Given this list of marker genes COP1, CTU1 (cytosolic thiouridylase subunit 1), SPATS2L, RNF145, NRP2, ZDHHC17, ERN1, TMEM170B, RCN1, NFIX, ADH7 (NCBI Gene Id 131), TMEM128, ACBD3, DTX4, HCLS1, NUP58, PNPT1, NPLOC4, CCND2, SLC39A1, UTP4, LINC02291, ATF4, SLFN12, PNP, ASF1A, IRGM, PTCH1, TERT, RARRES1, PRR14L, TRA2B, ZCCHC9, ITGAL, PPP1CB, TMEM176B, PARP12, DIS3, ZFAND3, ABITRAM, AMMECR1L, MAPK9, RND1, CASP7, UNC5A, PGGT1B, PLSCR1, PIAS1, FOXP4, RSPO2, CDKN1A, ARHGEF3, ITGA8, USP42, MTHFD2, PIK3R3, AK2, ROBO1, PRKD1, ZNF784, HAPSTR1, ADAMTS1, SLC39A14, PRDM1, LRCH3, TOMM20, TPD52L2, PTPN12, MOB1B, JADE1, PYCR1, TBC1D12, IL1RN, LHFPL6, SLC28A2, TXNRD1, POLR1F, ANXA7, CFB, DNMT3L, SOCS2, SYT13, BLNK, COL12A1, GPR85, UAP1, BACE1, ELP5, DIP2C, UBA3, PHTF2, PSMA6, CYFIP2, NSUN5, TTC39B, TLR3, FOXN2, FGF7, PER2, XAF1, GAS7, EPB41L3, COL27A1, KDELR3, MAGI3, MPRIP (myosin phosphatase Rho interacting protein), ATF1, CABLES2, PPP1R11, SLFN13, CD86, ZNRF1, WFS1, RSRC2, PDS5B, RAB11A, GARS1, STK40, IFT57, NEK4, TRAF3, TCF7L2 (NCBI Gene Id 6934), GPRIN3, NDUFAF4, GAS1, CEMIP (NCBI Gene Id 57214), PLEKHN1, BMP15, MS4A6A, PSMB10, STAT1, CGAS, LARP6, RIGI, TEAD1, SRSF3, NUPR1 (nuclear protein 1, transcriptional regulator), ZC3HAV1, ZFPM2, SAP30, SKIL, MRPL45, DOC2A, RBM7, RAB10, VAV2, PHLDA1, OTUD4, CLEC5A, PKN2, CSF2, MT2A, LIMS4, PLAGL1, APPL1, THBS2, IL13RA2, RFX5, GPR68, SUSD6 (NCBI Gene Id 9766), ZSCAN20, OLR1, PPM1K, ETS1, SRSF1, ARHGAP23, SLC12A2, GPD2, ACP3, C3, C1S, LAMC1, ZNF598, E2F5, MITF, PLK2, CLOCK, NUP62, FOXC2, WDR74, RNMT (NCBI Gene Id 8731), TJP1, AQP9, SLC6A9, RFTN1, MICU3, DNAJA2, TAP1, VWC2L, TCERG1, MTHFR, MMP9, PARP8, PAK1IP1, PSIP1, CLN5, DNAJA4, TMEM178A, RC3H2, IKBKE, here is a description of the gene set: Human Gene Set: GSE9037_CTRL_VS_LPS_4H_STIM_IRAK4_KO_BMDM_DN Genes down-regulated in comparison of untreated macrophages from IRAK4 deficient mice at 4 h versus those treated with LPS (TLR4 agonist) at 4 h. from publication Koziczak-Holbro M, Glück A, Tschopp C, Mathison JC, Gram H (PMID 18266302) IRAK-4 is an essential component of the signal transduction complex downstream of the IL-1- and Toll-like receptors. Though regarded as the first kinase in the signaling cascade, the role of IRAK-4 kinase activity versus its scaffold function is still controversial. In order to investigate the role of IRAK-4 kinase function in vivo, ‘knock-in’ mice were generated by replacing the wild type IRAK-4 gene with a mutant gene encoding kinase deficient IRAK-4 protein (IRAK-4 KD). Analysis of bone marrow macrophages obtained from WT and IRAK-4 KD mice with a number of experimental techniques demonstrated that the IRAK-4 KD cells greatly lack responsiveness to stimulation with the Toll-like receptor 4 (TLR4) agonist LPS. One of the techniques used, microarray analysis, identified IRAK-4 kinase-dependent LPS response genes and revealed that the induction of LPS-responsive mRNAs was largely ablated in IRAK-4 KD cells. In summary, our results suggest that IRAK-4 kinase activity plays a critical role in TLR4-mediated induction of inflammatory responses. species: Homo sapiens